Given this list of marker genes SLC19A1, TBC1D2B, RRAS2, STAT6, IGKC, PPOX, KRT1, IPO8, CDSN, ABCC9, HR, SRCAP, CFTR, JAK1, FOXN1, BRAF, FLG2, KARS1, LYN, CARD11, IL6ST, LRRC32, GNB2, IL6R, DPP9, CTLA4, IFIH1, SCNN1B, HSPA9 (heat shock protein family A (Hsp70) member 9), NECTIN1, SCNN1G (NCBI Gene Id 6340), PGM3, SCNN1A, ZNF341, IGHG2, KRT74, NEK9, DOCK8, MORC2, here is a description of the gene set: Atopic dermatitis (AD) or atopic eczema is an itchy, inflammatory skin condition with a predilection for the skin flexures. It is characterized by poorly defined erythema with edema, vesicles, and weeping in the acute stage and skin thickening (lichenification) in the chronic stage. species: Homo sapiens Atopic dermatitis Human Gene Set: HP_ATOPIC_DERMATITIS